Given this list of marker genes Cyba, Pik3c3, Noxo1, Mapk14, Prkca (NCBI Gene Id 18750), Ncf1, Rac2, Noxa1, Mapk3, Nox3 (NCBI Gene Id 224480), Mapk11, Ncf2, here is a description of the gene set: part of: RHO GTPase Effectors species: Mus musculus electronically inferred by orthology from the curated human pathway This event has been computationally inferred from an event that has been demonstrated in another species.<p>The inference is based on the homology mapping from PANTHER. Briefly, reactions for which all involved PhysicalEntities (in input, output and catalyst) have a mapped orthologue/paralogue (for complexes at least 75% of components must have a mapping) are inferred to the other species. Reactome Pathway: RHO GTPases Activate NADPH Oxidases